The following is a description of a gene set: from publication Tabula Muris Consortium (PMID 32669714) Mouse Gene Set: TABULA_MURIS_SENIS_BRAIN_NON_MYELOID_BRAIN_PERICYTE_AGEING studied in species Mus musculus, and this is the list of marker genes: Bsg, Gnb1, Rpl34-ps1, Tmem11, Jund, Ndufa1, Snai1, Spag7, Rps14, Mapk1ip1l, Insyn2a, Mrto4, Gpx4, Dctn3, Lrsam1, Chi3l1, Tulp3, Suclg1, Gm13889, S100a6, Nfu1, H2-Aa, Lxn, Dusp14, Cebpd, Smoc2, Ano3, Pdlim2, Atf3, Slc25a3, Mpc1, Ap4s1, Eva1b, Mrpl35, Faim, Zfand2b, Usf2, Cd9, Cd63, Ndufb7, Gng5, Ndufs8, Csrp2, Bckdha, Ndufa11, Edf1, Snrpb, Pdgfa, Kdm6b, Rab3a, Tspo, Spsb2, Mrps18c, Zfpl1, Mpc2, Etfb, Tmem160, Rps3, Sin3b, Gp1bb, Ypel3, Sar1b, Klf4, Nabp2, Myl9 (NCBI Gene Id 98932), Ddah2, Gadd45gip1, Chrac1, Anp32a, Skic8, Polr2a, Txndc17, Vkorc1, Cox5a, Ctsl, Psmc3, Ramp1, Apoe, Fbxl7, 1810037I17Rik, Chd4, Rpl9, Serf2, Cdk2ap2, Ddhd2, Akt1s1, Lamtor1, Junb, Cdc123, Ptgr1, Mif, Myl12a, Babam1, Med28, Wdr91, Eif5a, Lsm4, Selenbp1, Bcl7c, Atp5f1d, Spcs1, Zic2, Snrpd3, Pih1d1, 2010320M18Rik, Mrps35, Epb41l4a, Sem1, Vps29, Rex1bd, Mrps18a, Oga, Ndufa5, Atp5pf, Selenow, Brcc3, Ndufb8, Mocs2, Sys1, Bcr, Gpatch4, Twf1, Krt15, Rabepk, Zfp524, Ndufv2 (NADH:ubiquinone oxidoreductase core subunit V2), Mnt, Nexn, Tpt1, Polr2i, Bud23, Npm1, Prkrip1, Cfl1, Spint2, H2bc4, Commd7, Cdc37, Prrc2a, Mrpl23, Rrad, Cadm4, Birc6, Nfic, Fxyd5, Laptm4a, Hmgn1, Clic1, Lamtor2, Eif3i, Hexa, Atp5mc2, Lsm2, Ndufs3, Nsmce1 (NCBI Gene Id 67711), Psmc2, Pfdn1, Rpl35, Sst, Trappc2l, Rheb, Usp2, Mon2, Arl6ip4, Hmgn3, Anxa1, Cox6a1, Pfdn5, Tomm6, Ppp1r11, Fis1, Mxd4, Bcas3, Apold1, Ndufa7 (NADH:ubiquinone oxidoreductase subunit A7), Ldhb, Cystm1, Rps7, Ehd4, Ccnl1, Chchd10, Mpv17l2, Clpp, Iws1, Rpl32, Rpl6, Csnk2b, Gps2, Rassf1, Idh2, Plekhb1, Pmf1, Tmem14c, Pfn1, Cldn11, Pold4, Psmc5, Dbndd2, Lox, Mmp24os1, Ndufb6 (NCBI Gene Id 277815), Trex1, Dctn6, Dtd1, Cox5b, Rps18 (NCBI Gene Id 20084), Ptma (NCBI Gene Id 19231), Eif6, Zfp709, Ube2m, Cox4i1, Rbm8a, Nr4a2, Col6a1, Ccdc124, Rhoc, Irf1, Dgcr6, Arl3, Dynll1, Mdh1, Rpl24, Dusp16, Pkd2, Gimap4 (NCBI Gene Id 26966), Il33, Tubb6, H3f3a, Lmna, Cdkn1a, Cox6c, Zfp326, Mrpl28, Mrps24, Rnaset2b, Samd4, Phka2, Mrps11, Vps72, Phlda3, Gstt1, Eif1ax, Higd2a, Bmyc, Ubxn4 (NCBI Gene Id 67812), Ndufa4, Atp6v0e, Coa3, Mea1, Ppib, Tnfrsf12a (NCBI Gene Id 98086), Cstb, Sfn, Med29, Ndufa9, Tceal8, Ranbp1 (NCBI Gene Id 19385), Bpgm, Selenom, Rasgrp2, Nsd3, Hmgb2, Zfp560, Tssc4, Sncg, Bloc1s1, Mapk6 (NCBI Gene Id 70413), Pebp1, Ssna1, Arpc1b, Atp5if1, Trarg1, Tmed9, Fau, Anp32b, Sub1, Copz2 (NCBI Gene Id 80532), H2-K1, Tmem176b, Rps19, Fam204a, Trim56, Idh3g, Ndufa4l2, Ifi30, Prg4, Cox8a, Yipf3, Plpp3, Cox14, Tceal9, Pkig, Calm2, Tpm2, Mdh2, Atp5pb, Ptpn1, Capg, Mrpl17, Ildr2, Psmb6, Gadd45g (growth arrest and DNA-damage-inducible 45 gamma), Drap1, Pin1, Ninj1, H2az2, Daam2, Banf1, Mospd3, Id1, Manf, Foxs1, Fam111a, Cdc42ep3, Ift43, Shisa5, Nbl1, Ndufb10, Itga3, Fam89b, Gtf2h5, Vcf1, Med19, Ercc1, Sf3b4, Dcaf13, Zcchc17, Hmg20b (NCBI Gene Id 55419), Naxe, Pdcl3, Tomm5, Slk, Mt1, Rpl10a, Dpm1, Cryab, Pacs1, Cand1, Plekho1 (NCBI Gene Id 67220), Ctsz, Hmgb1, Tbkbp1, Arpc3, Polr1d, Pttg1, Bri3, Rpl18a, Dnajc1, Anapc11, Rpl41, Snu13, Mir24-2, Lrrc8a, Dbi, Eif4ebp1, Snrpd2, Gng10, Marf1, Cdc42ep5, Uqcrb, Arhgdia, Eif3k, Ube2k, Gng11, Sh3bgrl3, Nat8l, Lgals3 (NCBI Gene Id 16854), Ndufb11, Chchd7, Wbp2, Cavin3, Snrpa, Rplp0, Psma6, Mcm3ap, Gstp1, Uqcrq, Iscu, Naa80, Sarnp, Lpar1, Ahnak, Ier2, Tppp3, Rnd1, Map2k2, Dnajc4, Cebpb, Mt2, Cxcl1, U2af1, Timm13, Nbdy, Abl2, Fam171b, Use1, Btf3, Psma7, Nt5dc3, Ndufb9, Tmem9, Psme2, Sod1, Mustn1, Krt14, Tmsb4x, Rpl14, Atp6v1f, Srsf5, Slc25a5, Med10, Elob, Eva1c, Rabac1, Rap1a, Ubxn1, Oaz1, Hes1, Akr1a1, Rpsa, Srpk2, Maz, Commd1, Ubb, Leng1, Reep5, Crip1, Klf13, Tma7, Pkn2, Sdhc, Ap2s1, Mettl3, Myl6, Sfxn1, Nfkbia, Cmc2, Dynll2, Slc16a11, Hspb2, Dhx58, Cox4i2, Rps11, Fkbp2, Ccdc80, Akap5, Rps10, Spr, Nme2, Chmp2a, B230217C12Rik, Pi16, Il11ra1, Sdc4, Cisd1, Tbcb, Vasp, Rpl36, Ift20, Mgp, Jkamp, Atp5mc1, Ubald1, Psmb4, Hbegf (heparin-binding EGF-like growth factor), Rbm26, Selenok, Rasd1, Ino80e, Atp5mf, Tmsb10, Fxyd1, Smdt1, Atp6v1g1, Sat1, Rpl13, Rrp15, Atp6v0c, Naca (NCBI Gene Id 404597), Ndufc1, Cope, Tmed3, Cd74, Hsd17b10, Ncoa3, Atp5pd, Cetn2, Anxa2, Erp29 (endoplasmic reticulum protein 29), Ifitm2, Mien1, Exosc7 (exosome component 7), Acy1, Abi3, Ifitm3, Dynlrb1, Vamp8, Tbc1d22b, Pabpn1, Prdx5, Ddrgk1, Manbal, Nhsl1, Arl2, Bst2, Nol7, Syngr2, Acin1, Tuba4a, Zrsr2, Unc50, Myl12b, Ccdc85b, Dnajc9, Wdr81, Zscan26, Dad1, Thap3, Phb2, Rps20 (ribosomal protein S20), Ly6e (lymphocyte antigen 6 family member E), Elmo1, Rras, Cdkn1c, Inpp4a, Set, Stub1, Srp14, Ifi27, Ndufa12, Adrm1, Ang, Rbm3, Uba52, Dnajc3, Xirp1, R3hcc1, Mlst8, Son, Mllt6, Bex3, Uqcr10, Sgcb, Gm11627, Crtc1, Atp5f1c, Zfp414, Ndufa8, Smim20, Klf7 (Kruppel-like transcription factor 7 (ubiquitous)), Rdh13 (retinol dehydrogenase 13 (all-trans and 9-cis)), Cyc1, Rpl11, Psmd4, Polr2e, S100a11, Ndufs7, Cxxc5, Mrgpre, Ndufb2, Cnih4, Cltb, Ly6c1, Chp2, Scn2b, S100a1, Pigp, Tecr, Pigyl, Ly6a, Slc38a2, Ehmt2, Ndufa2, Atg3, Cuedc2, Vegfb, Atf5 (activating transcription factor 5), Mrps12, Pfdn6, C1qtnf6, Atp5po, Rpl27a, Polr3gl, Mgll, Ebna1bp2, Sod2, Aarsd1, Mgst3, Tcf7l2, Ube2v1, Ly6d, Cuta, H3f3b, Iqsec2, Fth1, Syf2, Ndufb4, Hilpda, Gadd45b, Scamp3, Txn2, Kpna4, Mettl23, Rplp1, Atg101, Psma1, Tmem203, Mrpl48, Grina, Ormdl3, Atp5mg, Camk1, B2m, Hint1, Rpl3, Cycs, Hcfc1r1, Map1lc3a, D8Ertd738e, Hax1, Slc45a4, Psma3 (proteasome subunit alpha 3), R3hdm2, Sumo1, Ltbp3, Rps2, Tln1, Sertad1, H2-D1, Psmb2, Ntmt1, Ybx1, Jtb, Emp3, Rnd2, Cbr1, Igfbp6, Nudt9, Pfdn2, Rpl21, Zfp622, Mrpl19, Grpel1, Smarcb1, Ndufs6, BC031181, Chchd2, Setd7, Sdhd, Atp5mc3, Rps9, Park7, Micos10, Rcn1, Cst3, Ppp1r14a, Prr13, Lamtor4, Tle5, Micos13 (mitochondrial contact site and cristae organizing system subunit 13), Pnrc1, Ndufa13, Swi5, Nedd8, Dgkh, Szrd1, Atp6v0b, Polr3h, 1700025G04Rik, C1qtnf2 (NCBI Gene Id 69183), Mrps26, Cyba, Pqbp1, Npc2, Uqcrh, Gata3, Ubb-ps, Psmb1, Vps28 (vacuolar protein sorting 28), Ssr4, Akap11, Ldb1, Cdkn2d, Uqcc2, Vgll4, Ciao2b, Gabarap, Emc4, Prkra, Nudt16, Capns1, Lum, Gstm1, Smim14, Pcp4l1, Pomp, Btg2, Ier3, Rpl17 (ribosomal protein L17), Mettl26, Ppdpf, Trappc6b, Tagln2, Gabarapl2 (NCBI Gene Id 93739), Ssu72, Hnrnpr, Gpx1, Ppp1r35, Psmd7, Tmem234, Serbp1, Cirbp, Kl, Rad21, Emd, Rgs2, Psmb3, Lmod1, Cabp1, Dapk1, Hsbp1, Rps15, Scand1, Mtx3, Klf5, Tmem250, Fn1, Enho, Nupr1, Pagr1a, Dapk3, Ptpn5, Rps5, Rplp2, Zfp36, Ccdc107, Snrpc, Id3, Hmgn2, Ftl1, Ppfia2, Nod1 (NCBI Gene Id 232000), Rpl13a, Thap7, Hmgn5 (NCBI Gene Id 50887), Ost4, Ptms